The following is a description of a gene set: studied in species Homo sapiens part of: Centrosome maturation Reactome Pathway: Recruitment of mitotic centrosome proteins and complexes The mitotic spindle becomes established once centrosomes have migrated to opposite poles and the nuclear envelope has broken down. During this stage, interphase centrosomes mature into mitotic centrosomes recruiting additional gamma TuRC complexes and acquiring mitosis-associated centrosomal proteins including NuMA, Plk1 and CDK11p58., and this is the list of marker genes: HSP90AA1, DCTN1, DCTN3, CSNK1D, CLASP1, CEP290, YWHAE, TUBG1, CEP70, TUBGCP3, CEP192, HAUS3, CEP72 (centrosomal protein 72), CSNK1E, CEP250, HAUS6, CETN2, PRKAR2B, PRKACA, TUBB4B, HAUS1, SFI1, ODF2, CPAP, CNTRL, CDK11B, DYNC1I2, PCNT, CEP164 (centrosomal protein 164), CEP135, DCTN2, PCM1, CEP131, TUBG2, SSNA1, CEP78, MZT1, HAUS8, SDCCAG8, CDK5RAP2, OFD1, TUBB, ACTR1A, TUBB4A, DYNC1H1, CEP43, CDK11A, CCP110, HAUS5, TUBGCP2, MAPRE1, NME7, TUBGCP5, PLK4 (polo like kinase 4), PAFAH1B1, PLK1, DYNLL1, CEP152, CEP63, CEP41, CEP76, NEK2, CEP57, HAUS4, NDE1, NEDD1 (NCBI Gene Id 4732), PPP2R1A, MZT2A, MZT2B, TUBGCP6, TUBA1A, CDK1, YWHAG, ALMS1, HAUS2, AKAP9, NINL, TUBGCP4, TUBA4A, CKAP5, HAUS7